Given this list of marker genes Mboat2, Lpcat3, Mboat7, Nr1h2, Lpcat2, Lpcat4, Dbi, Pla2g4a, Nr1h3, Pla2g2f, Lpcat1, Pla2g4c (NCBI Gene Id 52126), here is a description of the gene set: Mouse Gene Set: GOBP_PHOSPHATIDYLCHOLINE_ACYL_CHAIN_REMODELING Remodeling the acyl chains of phosphatidylcholine, through sequential deacylation and re-acylation reactions, to generate phosphatidylcholine containing different types of fatty acid acyl chains. species: Mus musculus